Given this list of marker genes RBM19, SLC27A2, GAPDH, CLK2, ZW10, CD58, PI4K2A, CD6, CD48, GEM, CTSL, ARHGAP5, PRDX3, LAPTM4B, CA2, HS2ST1, PDE4B, IGF2R, MDFIC, STK25, CDK17, VOPP1, ATG14, MAP3K4, SERPINB8, PLAGL1, IRF1, ALKBH1, PTTG1, ACSL1, CCR7, FLNB, KHDC4, TNFRSF9, PFKM, TNFRSF10B, GATM, PAQR3, NFIA, BHLHE40, NR3C1 (NCBI Gene Id 389335), PTPRO, MAP2K4, ATF3, TM9SF1, ID3, HIVEP1, MMP8, MBNL2, GPD2, UBE2K, JAK2, ACYP1, MTMR1, LPXN, PLCB1, HLTF, SF3A1, SLC1A4, GSTO1, EYA1, COL6A3, DDX17, EPHB6, ADARB1, COX7A1, PDE3B, DNAJC6, ZBTB18, CCL20, GNG5, DHX8, TCEAL1, SPAG6 (sperm associated antigen 6), IGFBP4, MSL3, ATP8A1, CCDC28A, ZEB2, MMD, SPTLC2, TMEM268, LSR, SNX4, TGIF1, RPL37A, B4GALT4, CPD, CGRRF1, TSC22D1, TIMP1, SYNGR3 (NCBI Gene Id 9143), CDKN1A, COG5, ZNF140, ATP1B1, BCL6, PATZ1, DHRS3, SLAMF1, STK38L, HBEGF, NPTX1, TEX261, PGAP1, ABTB2, ZNF266, ZNF84, RGS16, POLA1, SERPINE2, OSER1, EIF4G3, MINPP1, ISCU, FXR1, BARD1, PASK, UBFD1, CD83 (NCBI Gene Id 9308), KRT19 (keratin 19), ACSL4, POLD3, ELP1, RNF103, USP34, ANGEL2, NECTIN3, EED, CD2, IL23A, SMURF1, DCAF8, CD27, FOXO1 (forkhead box O1), INPP5F, ZNF135, PDXK, CD9, LPL, PCDHGA12, OPCML, HES1, CPSF6, CKMT2, FOXC1, FMR1, CEP170, PCSK1, PLP2, APOBEC3B, SUSD6, ZNF143, BMP2K, RFTN1 (NCBI Gene Id 23180), ZNF189, BTN3A2, JUN, SMS, UBE2E3, IFNGR1, IL1RL1, RGS10, ADGRE5, BASP1, MOGS, BCL7A, ACYP2, GDE1, PDE8A, RAB29, TRAK1, GGCX, IL16, TOX3, ADA, NFKBIE, ABCB7, FAM3C, ZNF318, SEPTIN6 (NCBI Gene Id 23157), DZIP1, REL, NR4A2, BPGM, PLS3, PTK2, PDHA2, LITAF, NUMB, TLL2, VPS13D (vacuolar protein sorting 13 homolog D), TRAF1, ARHGAP1, CYP51A1, MAPKAPK5, SKIC8, DMXL1, IL6, here is a description of the gene set: from publication Anandasabapathy N, Victora GD, Meredith M, Feder R, Dong B, Kluger C, Yao K, Dustin ML, Nussenzweig MC, Steinman RM, Liu K (PMID 21788405) studied in species Homo sapiens Genes up-regulated in brain microglia versus spleen CD8+ dendritic cells. To understand the functional relationship between brain dendritic cells (brain DCs) and other myeloid cells, we compared the gene expression profile of m/chDCs to that of bone marrow monocytes, brain microglia and classical spleen CD8+ and CD8- DCs. In order to obtain enough brain DCs for mRNA extraction, we expanded brain DCs with in vivo Flt3L treatment before purification. Human Gene Set: GSE29949_MICROGLIA_BRAIN_VS_CD8_POS_DC_SPLEEN_UP